Given this list of marker genes Patl1, Pus7, Tmem185b, Ccdc85a, Bmpr2, Agtpbp1, Prkar1a, Polq, Nup50 (nucleoporin 50), Tsnax, Adamts6, 2310002L09Rik, Ebf1, Map4k3, Nek9, Rtp2, Arhgap29, Pate4, Prkci, Rdh10, Mmd (NCBI Gene Id 69866), Neo1, Czib, Mrps14, Igfbpl1, Nexmif, Ino80, Dmd, Tanc2, Ccn2, Mrps33, Cdh16, Tbc1d12, Ipo8, Cep152, Phyh, Phf23, Prelid3b, Dst, Kcnmb4, Mctp2, Rspry1, Eif5b, Tmem196, Ermard, Rasgrp1, Zfp28, Tgm3, Camsap1, Fos, Riok2, here is a description of the gene set: studied in species Mus musculus from publication Chen Y, Wang X (PMID 31504780) Mouse Gene Set: MIR_3110_3P Genes predicted to be targets of miRBase v22 microRNA mmu_miR_3110_3p in miRDB v6.0 with MirTarget v4 prediction scores > 80 (high confidence targets).